The following is a description of a gene set: Complete atrioventricular canal defect A congenital heart defect characterized by a specific combination of heart defects with a common atrioventricular valve, primum atrial septal defect and inlet ventricular septal defect. Human Gene Set: HP_COMPLETE_ATRIOVENTRICULAR_CANAL_DEFECT species: Homo sapiens, and this is the list of marker genes: PRKACA, INTU, PTPN11, TRIO, CIROP, CDC45, NKX2-6, ZIC3, WDPCP, TBX5, TBX1, GATA6, IRX5, GDF1, HYLS1, PUF60, NKX2-5, ACVR2B